Given this list of marker genes Col2a1, Phex, Mmp9 (matrix metallopeptidase 9), Fgfr2, Tuft1, Pdgfa, Ahsg, Tgfb3, Vdr, Mmp2, Bmp1, Col4a2, Col6a1, Col4a1, Col5a1, Tgfb2, Bmp5, here is a description of the gene set: from publication Kang HY, Shyr CR, Huang CK, Tsai MY, Orimo H, Lin PC, Chang C, Huang KE (PMID 18838539) Mouse Gene Set: KANG_AR_TARGETS_UP Genes up-regulated in osteoblasts from wild type male mice compared to those with AR knockout. species: Mus musculus While androgen receptor (AR)-deficient mice developed osteopenia in endochondral bones due to the high bone turnover with increased bone resorption by osteoclasts, little is known about the mechanism of intramembranous bone loss contributed by AR in osteoblasts. Here, we discovered a dramatic decrease in the area of calcification, new bone, and the number of osteocytes in calvaria from AR-deficient mice related to a reduction in mineralization caused, in part, by the diminished activity of AR-deficient osteoblasts. Enforced AR expression in differentiated osteoblasts boosts mineralization while knockdown of AR expression prevents androgen-induced mineralization. We identified the tissue-nonspecific alkaline phosphatase (TNSALP) and several members of small integrin binding ligand N-linked glycoprotein (SIBLING) gene family as androgen target genes required for AR-mediated bone formation. We show that inorganic phosphate (P(i)) levels and TNSALP activity increased in response to androgen/AR and P(i) signals increase the expression and translocation of AR. The ectopic expression of TNSALP or P(i) partially rescued the bone loss due to AR deficiency. Thus, androgen/AR signaling plays an essential role in bone formation by coordinating the expression of genes associated with phosphate regulation.